Given this list of marker genes Zdhhc6, Zdhhc12, Pla2g4a, Dgat2l6, Sirt6, Sirt5, Naa10, Kat6a, Dgat1, Apoa1, Naa40, Plaat1, Brpf1, Msx3, Nmt1, Zdhhc25, Plaat3, Gm4952, Pla2g15, Lpgat1, Sirt7, Crot, Atf2, Zdhhc22, Pdcd5, Pigw, Lpcat4, Sirt4, Mboat7, Zdhhc2, Ing3, Lpcat2b, Zdhhc1, Acsm1, Tgm2, Elovl7, Naa60, Ncoa3, Zdhhc17, Gpat4, Mboat2, Lpcat1, Nags, Zdhhc5, Naa80, Dlat, Brd1, Hadha, Mettl8, Zdhhc20, Esco2, Hhat, Apoa5, Nat8f2, Cln5, Sirt1, Gnpnat1, Zdhhc18, Keg1, Ykt6, Nat8, Kat14, Crebbp, Abhd5, Mboat4, Nat1, Pafah1b3, Gtf2b, Zdhhc23, Naa15, Nmt2, Sptssb, Awat1, Hat1, Serinc5, Acsm5, Pnpla3, Elovl3, Sptlc1, Jade2, Ifnb1, Nat8f7, Sat2, Zdhhc24, Nat3, Dgat2, Med24, Agpat1, Zdhhc8, Zdhhc21, Nat8b-ps, Glul, Pnpla2, Ing4, Zdhhc3, Casd1, Taf1, Acnat1, Alas2, Crat, Gtf3c4, Naa50, Cers4, Nat8f1, Pnpla1, Acsm4, Pla2g4c, Gpat2, Porcn, Sirt3, Lipt1, Cers6, Clock, Nat14, Gm6993, Glyatl3, Awat2, Zdhhc7, Acat3, Lclat1 (NCBI Gene Id 225010), Nat2, Lpcat3, Gpat3, Ep300, Prdx6, Apoa4, Oga, Sphk1, Agpat5, Dbt, Smarce1, Cers5, Nupr1, Pdcd5-ps, Kat2b, Acat1, Serinc1, Kat2a, Agpat4, Osgepl1, Meaf6, Sptlc3, Sat1, Mcat, Baat, Phf10, Nap1l2, Mboat1, Kat8, Tafazzin, Agpat2 (NCBI Gene Id 99244), Bloc1s1, Elovl6, Cers1, Zdhhc13, Sh3glb1, Acsm2, Mcm3ap, Nat8f6 (NCBI Gene Id 100504710), Acaa1a (NCBI Gene Id 52057), Abhd4, Fcor, Elovl5, Cers2, Naa30, Gcat, Nat10, Sirt2, Plaat5, Aanat, Gpam (NCBI Gene Id 14732), Cpt1a, Scp2, Kat7 (K(lysine) acetyltransferase 7), Cers3 (NCBI Gene Id 74802), Soat2, Jade1, Pafah2, Kat6b, Zdhhc14, Kat5, Elovl4, Lrat, Elovl2, Pafah1b2 (NCBI Gene Id 70308), Satl1, Soat1, Zdhhc15, Nat8f3, Tlcd3b, Osgep, Lipt2, Acaa1b, Usp22, Naa11, Abhd14b, Taf10, Ncoa1, Fasn (fatty acid synthase), Naa16, Tmem68, Gnpat, Cpt2, Sptssa, Cdyl, Oxsm, Tada2a, Acnat2, Abhd8 (abhydrolase domain containing 8), Pygo2, Chat, Acsm3, Elovl1, Brpf3, Naa25, Slc27a3, Cpt1b, Nat8f4, Lcat, Naa12, Zdhhc4, Mogat1, Dlst, Hgsnat, Pla2g4e, Nat8f5, Atat1, Bcas3 (NCBI Gene Id 76344), Taf9, Zdhhc16, Glyat, Alas1, Nat9, Mogat2, Naa20, Zdhhc9, Apoa2, Zdhhc19, Oacyl, Nat8l, Lpcat2, Zdhhc11, Brca2 (NCBI Gene Id 12190), Hadhb, Prdx6b, Acat2 (NCBI Gene Id 21456), Acaa2, Elp3, Aspg, Sptlc2, Agpat3, Esco1, Apoe, Ogt, Cpt1c, here is a description of the gene set: Mouse Gene Set: GOMF_ACYLTRANSFERASE_ACTIVITY_TRANSFERRING_GROUPS_OTHER_THAN_AMINO_ACYL_GROUPS species: Mus musculus Catalysis of the transfer of an acyl group, other than amino-acyl, from one compound (donor) to another (acceptor).